Given this list of marker genes SLC37A4 (NCBI Gene Id 84965), NCF2, CYBA, NCF1, CYBB, here is a description of the gene set: Human Gene Set: HP_ABNORMAL_PHAGOCYTOSIS Abnormal phagocytosis studied in species Homo sapiens An abnormal functioning of phagocytosis. Phagocytosis is an elegant but complex process for the ingestion and elimination of pathogens, but it is also important for the elimination of apoptotic cells and hence fundamental for tissue homeostasis. Phagocytosis can be divided into four main steps: (i) recognition of the target particle, (ii) signaling to activate the internalization machinery, (iii) phagosome formation, and (iv) phagolysosome maturation.